The following is a description of a gene set: Genes negatively differentially expressed in cell type: Neutrophil upon treatment with cytokine: TNF-α in mouse lymph nodes in vivo. Mouse Gene Set: CUI_NEUTROPHIL_TNFA_RESPONSE_DN Cytokines mediate cell-cell communication in the immune system and represent important therapeutic targets. A myriad of studies have highlighted their central role in immune function, yet we lack a global view of the cellular responses of each immune cell type to each cytokine. To address this gap, the authors created the Immune Dictionary, a compendium of single-cell transcriptomic profiles of more than 17 immune cell types in response to each of 86 cytokines (>1,400 cytokine-cell type combinations) in mouse lymph nodes in vivo. A cytokine-centric view of the dictionary revealed that most cytokines induce highly cell-type-specific responses. For example, the inflammatory cytokine interleukin-1β induces distinct gene programmes in almost every cell type. A cell-type-centric view of the dictionary identified more than 66 cytokine-driven cellular polarization states across immune cell types, including previously uncharacterized states such as an interleukin-18-induced polyfunctional natural killer cell state. studied in species Mus musculus from publication Cui A, Huang T, Li S, Ma A, Pérez JL, Sander C, Keskin DB, Wu CJ, Fraenkel E, Hacohen N (PMID 38057668), and this is the list of marker genes: Ccl6, Dhrs7, Fxyd5, H1f2, Rassf3, Cd300ld, Gsn, Stk17b, Fos, Rgs2, Mmp9, Taldo1, Fgl2, Cotl1